Given this list of marker genes SNHG20, NPTX1, SLC16A5, MRPL12, SLC38A10, ENSG00000279801, CSNK1D, SLC9A3R1-AS1, MAFG, TBC1D16, TSEN54, CDR2L, SCARNA16, TMEM105, METRNL (meteorin like, glial cell differentiation regulator), NUP85, LLGL2, CD300A, BTBD17, FSCN2, NAT9, FOXK2, CD7, FAAP100, ENSG00000261924, RNU6-227P, CBX4, RNU6-24P, WDR45B, RNY4P36 (RNY4 pseudogene 36), TEX19, CYBC1, OXLD1, MRPS7, KCTD2, MRPL58, MIR4738, LINC01973, SLC25A19, ASPSCR1, CD300LB, BAHCC1, RPL32P31, RENO1, MIR6787, CDC42EP4, LINC01977, RAB37, MIF4GD-DT, TEPSIN, HGS, AANAT, MIR3186, TMEM104, RECQL5, LINC03048, ENSG00000264985, ATP5MGP6, ZACN, RN7SL454P, TRIM80P, LINC01971, LGALS3BP, MRPL38, DNAH17, RPL7P49, CD300LF, ENSG00000200063, EIF4A3, PYCR1, RAB40B, RPL31P7, TEN1-CDK3, LINC01993, ENSG00000297995, SRP68, USP36, SOCS3-DT, SOCS3, CD300E, FBF1, CYCSP40, OTOP3, RBFOX3, RNF213-AS1, TMEM235, P4HB, MIR3065, SSTR2, GGA3, PVALEF, BAIAP2, ARL16, ST6GALNAC1, BIRC5, TSPAN10, LINC00868, ENPP7, SLC25A10, CCDC137, ENSG00000267568, ATF4P3 (activating transcription factor 4 pseudogene 3), RNF157-AS1, ACTG1 (NCBI Gene Id 71), DUS1L, DNAI2, FN3K, NPB, PYCR1-AS1, RPL36AP7, PCYT2, MIR3678, GPS1, SRSF2 (serine and arginine rich splicing factor 2), BAIAP2-DT, CEP295NL, HEXD-IT1, NARF-AS2, SAP30BP, UBE2V2P2, TMEM94, WBP2, LINC00482, TNRC6C, MIR6786, TEN1 (TEN1 subunit of CST complex), UBALD2, NT5C, ENSG00000262147, ENSG00000298376, MIR4525, SMIM5, MAFG-AS1, SEC14L1, CBX8, SNORD1B, ATP5PD, RNU4-47P, MGC16275, CBX2, SEPTIN9-DT, RAC3, ENSG00000284526, CD300LD, PDE6G, RNU6-362P, SNORD1A, ATG12P1, THA1P, ENSG00000309113, NHERF1, ENSG00000289070, SECTM1, SEPTIN9 (septin 9), SLC26A11, LINC01979, USH1G, LINC01987, AFMID, CARD14, QRICH2, CD300LD-AS1, TTYH2, RPTOR, RNA5SP448, C1QTNF1-AS1, UNC13D, CANT1 (calcium activated nucleotidase 1), SYNGR2, HID1-AS1, MXRA7, CPSF4L, MGAT5B, AATK, MIR636 (microRNA 636), PRPSAP1, C17orf99, JMJD6, RNU6-938P, LINC02078, SIRT7, CYTH1, ENSG00000305265, RHBDF2, LINC01978, FDXR, VCF1, ENSG00000262833, RNU1-80P, GPR142, CHMP6, GPRC5C, CEP131, RPL9P29, CD300H (CD300H molecule (gene/pseudogene)), MIR4740, MIR6785, SDK2, ENDOV, SGSH, FN3KRP, ARMC7, SLC39A11, CASKIN2, MYO15B, LINC02074, MILIP, HID1, DCXR, TK1, NARF-IT1, ST6GALNAC2, OTOP2 (NCBI Gene Id 92736), CENPX, NPLOC4, CDK3, MIR3615, PPP1R27, ENSG00000302723 (NCBI Gene Id 124904055), RNU6-638P, SUMO2, HEXD, FOXJ1, DCXR-DT, GALR2, CCDC40, NARF, SPHK1, EXOC7, ZNF750, GCGR, TMC6, NOTUM, SNHG16, NARF-AS1, H3-3B, LINC02092, ENSG00000260005, DNAH17-AS1, SMIM6, NDUFAF8, FASN, UTS2R, PGS1, SLC16A3, SCAT1 (S-phase cancer associated transcript 1), CYGB (cytoglobin), UBE2O, ENSG00000294318, MTNAP1, ACOX1, MYADML2 (NCBI Gene Id 652040), GALK1, C1QTNF1, ENGASE, MIR338, UNK, ALYREF, MIR1268B, RNU6-625P, RN7SL236P, MCRIP1, RPL38, CCDC57, POLR3KP2, MIR6516, MIF4GD, LINC02080, RN7SL573P, ENSG00000287403, MIR1250, OGFOD3, LINC00469, GAA, RNF157, RNF213, COG1, KIF19, ENSG00000294024, GRB2, JPT1, MIR6868, TRIM65, B3GNTL1, RNU6-97P, LRRC45, TIMP2, METTL23 (methyltransferase 23, arginine), LINC01970, MIR4739, RPL23AP87, ENSG00000261335, TBCD, FADS6, SNORD1C, PRCD, ITGB4, ANAPC11, ENSG00000295072, TMC8, GRIN2C, EIF5AP2, MFSD11, RFNG, SAP30BP-AS1, ARHGDIA, RPL12P37, MIR4730, MIR4316, MIR657, TRIM47, EVPL, CD300C, here is a description of the gene set: species: Homo sapiens Human Gene Set: chr17q25